Given this list of marker genes PPIEL, HBEGF, HNRNPC, GCLC, PHF3, HPCA, ADAMTS3, MSX2, SKAP1, LIPC, LRBA, NRK, PCDH1, ADH6, PTH, NDEL1, PDE3A, SYNC, ATP6V0A1, MET, CCL13, EFNB3, PDCD10, EVI2A, GGA3, PTPRCAP, PDHA1, INSL4, RAB9A, HNRNPD, ITIH2, PRLR, LRP1, EPHA1, STAT5B, DBT, CD8A, SGPL1, RBM6, ARNT2, CYP39A1, SLC6A12, FUT4, CHRNE, DUSP5, DCT, TCEA2, GYPB, CHRNA7, SLC6A1, SEC23A, USP1, DNALI1, ADSL, SLC1A3, ELF4, IL18R1, RPS6KA3, AHCY, SCD, LCP2, PLD6, RBM3, TRAF6, SP140, DSC2, HSF2 (NCBI Gene Id 3298), ATP7A, RUFY3, CYP19A1 (NCBI Gene Id 1588), DOCK2, BAP1, MMP7, RIT2, FADS1, USP9X, RBM5, SMAD4 (NCBI Gene Id 4089), EML4, PFN1, KIFC1, HCLS1, PDE4DIP, ENTPD1, BDH2, LDHD, PTPRK, PPP2CB, IL16, NFYB, ALDH8A1, CYB5A, ERCC5, DIS3, POLR2A, PPOX, C1QTNF6 (C1q and TNF related 6), DDX18, UBE2N, SP3, PCYT2, SIAH1, RPS6KB1, APPBP2, PPP3CA, KIF14, EIF4A1, CTNND1, HELZ, UBR2, DCTD, VCAM1, LRRFIP2, ASMTL, RNF168, ADAM12, MPP3, CXADR, LINS1, POFUT1, MYO5B, HLA-DQB1 (major histocompatibility complex, class II, DQ beta 1), CACNA1I, CKS2, TOPBP1, STAT3, HIBADH, QPCT, AP1G1, HOXD9, ITPKB, WNT5A, EGFR, MECOM, GDF11, RBBP6, COL17A1, ROPN1L, SOX9, ENPP5, DLX4, BCL2L2, HNMT, GM2A, PPP1R12C, ADAM11, IGFBP1, AVPR1A, TFDP2, IL1R1, THOC1, ATP6V0B, PTGFRN, C3AR1, CCL28, MTA1, RAB6A (NCBI Gene Id 5870), N4BP1, H2AJ, SIRT5, FRZB, FOLH1, FAN1, VASP, RAB7A, PTPRN2, SOX7, PDCD2, CYBB, CRABP2, CEPT1, LIG4, AKAP6, ZNF507, KCNK1, TIE1, NCOR1, SLC30A5, FBLN1, ABCC1, NRP2, SLC9A6, MGAT2, MITF, PLCL1, GSTA2, CNKSR1, ARNT, CYBRD1, PHLDA1, SYK, MYB, ATF7, SEC22A, ATP5MJ, GNPNAT1, NRCAM, MEF2C, SLCO2A1, CHL1, PRG2, RBP4, CXCR4, RAB1B, PCSK5, here is a description of the gene set: The accumulation of DNA damage and mutations is considered a major cause of cancer and aging. While it is known that DNA damage can affect changes in gene expression, transcriptional regulation after DNA damage is poorly understood. We characterized the expression of genes in human primary fibroblasts after exposure to three different kinds of cellular stress that introduces DNA damage: 4-nitroquinoline-1-oxide (4NQO), gamma-irradiation, or UV-irradiation. Each type of stress elicited damage specific gene expression changes of up to 10-fold. A total of genes had similar changes in expression of 3-40-fold after all three kinds of stress. We examined transcription in cells from young and old individuals and from patients with Werner syndrome (WS), a segmental progeroid condition with a high incidence of cancer, and found various age-associated transcriptional changes depending upon the type of cellular stress. Compared to young individuals, both WS and old individuals had similarly aberrant transcriptional responses to gamma- and UV-irradiation, suggesting a role for Werner protein in stress-induced gene expression. Our results suggest that aberrant DNA damage-induced gene regulation may contribute to the aging process and the premature aging in WS. Genes with GO annotation and up-regulated after DNA damage in cell lines from young donors. from publication Kyng KJ, May A, Stevnsner T, Becker KG, Kølvrå S, Bohr VA (PMID 15897889) studied in species Homo sapiens Human Gene Set: KYNG_DNA_DAMAGE_UP